Given this list of marker genes CNOT4 (NCBI Gene Id 4850), ASAP1, PHIP, PEX6, TENM3-AS1, THEMIS2, KCTD3, LINC01491, ANAPC15, NFE2L1, CCNI, RNA5SP150, ZNF81, BCO2, WLS (Wnt ligand secretion mediator), YAP1, MIR1244-3, H3-3B, FZD2, RABGAP1L-DT, GNL1, PCGF2, CLDND2, LGI4, PLCH2, JARID2, ABI2, LILRB3, PPP1R15A, TCAP, LMO4, SMAP2, ITPR1, RC3H1, GABARAP, ARHGEF1, LHX2, ST13, SAMD4A, NREP, SDC3 (NCBI Gene Id 9672), UBTF, HOXB2, BPTF, GNG12, ZBTB24, ATPAF1, RALA, ZNF771, IL21R (interleukin 21 receptor), WDTC1-DT, RAB35, RAP1GAP2, TM9SF3, CYFIP1, EEF1A1P18, POLI, MEIS2 (Meis homeobox 2), IRF2-DT, ADAMTS9, GIPR, ME1, MIR9-1HG, GDAP1, RBFOX3, IPO8, TOP3B, BMP7, PTPN4, PTPRD, FGFR4, ACVR1, PLOD1, MTERF4, RGL2, RNF217-AS1, SEC24B, ATAD2, ZMYM2, SMCHD1, TCF4, FGF5, PSMA1, ZNF385C, PLEKHA5, TSC22D1-AS1, MT-RNR1, THAP12, PAXBP1, SLC25A45, PDXK, RFX3-DT, CCDC66, KSR2, TMEM132B, LINC01145, TMEM164, TPR, LDB1, EMC8, TMBIM4, SHC4, PFKM, PRCD, ZNF148, SLC12A2 (solute carrier family 12 member 2), CLIC4, FAXDC2, GFRA1, RPL39, INTS3, NAV2, CERS6, SRCAP, HKDC1, SYDE2, CREBRF, PLCD3, ENC1, NDUFS7, NEO1, SMG9, BBIP1, DCAF13, TUBA1C (NCBI Gene Id 84790), ABCC8 (NCBI Gene Id 6833), SATB2-AS1, MRPL20, UPP2, OSBPL10, PRDM16-DT, GNG12-AS1, ENSG00000233230, SH3RF1, SRC, PCDH10-DT, TBC1D1, LAMTOR4, ITPRID2-DT, SHOC2, SAMD4B, ST8SIA2, CDC73, BBX, PPM1F, RC3H1-DT, SAP30BP, CABLES1, GEMIN6, AGAP3, LSM3, MFSD11, TAPBP, IL18R1, CUL4B, CORO1A, SEMA4D, SPRYD7, CACNA1D, PHF23, SPRYD3, PDZD7, PHF12 (PHD finger protein 12), CAND1, UBE2L3, GRK3, CHCHD7, C1QTNF2, ETS2, AP2A1, TRAV12-2, PUS7, SIRT1, USP22, USP27X-DT, GALE, CEP135, ACTB, PPP1R18, LINC01411, TEX38, CARHSP1, TENM4, LINC01138, GTF2I, STON1, SEMA3A, SLIT3-AS2, MED13L, DPAGT1, DUSP16, CALR, CDC14A, ASH2L, INO80, MAN1A2, FEM1B, CARMN, PIP4K2A, NIPBL, CELF2, ARL6IP4, CDK18, GALNT7, CXCL16, MDFIC, WDFY3, SATB1, DGKA, CBLN3 (NCBI Gene Id 651052), VAV2, ERC2, RBPMS-AS1, MACROH2A2, RAB35-AS1, PLA2G6, CDC123, SRPK2, KHNYN, UBR5, RGS16, HUNK, TIAL1 (NCBI Gene Id 8430), SNX27, LTBP3, BCOR, DLK2, PRDM16, ECE1, CLPB, RTN4, GABPB2, NEXN, RN7SL468P, TERF1, BMI1, KRTCAP2, RAPGEF2, COL13A1, RBPMS, CCT6B, DLC1, RNF217, ADORA1, HOXB-AS3, ZNF503-AS1, ST3GAL1, SLC12A5-AS1, WDR25, ZBTB48, MTAP, ZC3H4, COX6B1P7, CALHM2, DACT3-AS1, C22orf15, SLC29A3, CFAP418, RAI1, ANP32E, P2RX5, MAD1L1, KIF21A, BARHL2, PLEKHG3, NRL, YWHAB, HDGF, NDUFB8, CARMIL1, MCMBP, CCDC97, ARID4B, TSC22D1, MANF, WAC-AS1, NUDT5, NEDD4, TMEM232, DDI2, ISM1, LIG4, TMEM177, PMEPA1 (NCBI Gene Id 56937), NCOA2, ZNF703 (NCBI Gene Id 80139), MAML3 (mastermind like transcriptional coactivator 3), RAB4A, XRCC1, SLC35B3, CIZ1, KCNB1, MCTP1, DNAJC6, SCARA3 (NCBI Gene Id 7992), SLC25A32, PALS2, SH3BP5, KCNE2, TAB2, E2F5-DT, WDR26, SETP6 (NCBI Gene Id 100419178), MEF2C-AS2, EMC3 (NCBI Gene Id 55831), AKT1S1, DKK2, RAB8A, OSBPL2, RGS10, MAP2K5-DT, CRTC1, ANKRD17-DT, CD6, ZFHX2, RGS9, XPR1, FMC1-LUC7L2, STMN3, FRMD4B, EXOSC8, EGR3, ATP1B1, EIF3D, ARID1B, PRR3, SERTAD2, NCDN, ZNF687, CHD3, CNIH3, LINC01605, GVQW3 (NCBI Gene Id 387790), ENSG00000233577, SOWAHD, ENSG00000254839, DUTP7, LINC02093, NUS1, TRPC1, SAE1, DDX41, ANKHD1, KPNB1-DT, CPEB4, LRRC49, CHAF1A, SUPT6H, ATG101, HGSNAT, ALMS1, ARID3A, MYO5A, VPS25, GNAS, GCNT1, BICRA-AS2, RNF225, SRSF7, EMX2OS, FBRS, FOXB1, TLE5 (TLE family member 5, transcriptional modulator), LINC01089, EFHD2, ABCB9, RPS25, ZNF830, RAP1A, ZKSCAN2, PAX6, RPRD1B, B4GALT1, GATA6-AS1, QSOX1, HLA-F, SLC12A2-DT, MARF1, SNX15, FABP6-AS1, BAZ2B, LINC01003, EMC3-AS1, OVOL2, WAC, NEUROG2-AS1, CHST3 (NCBI Gene Id 9469), ENSG00000273582, TPM4, RUVBL2, UBE2E1, MSRB3, CNOT3, LCP2, PLEKHG1, USP34, MIR124-1HG, NCOA7 (NCBI Gene Id 135112), THAP10, ILF3-DT, PAFAH2, TRIP6, MICAL3, NOL4L, PIPOX, KRI1, NR2C2, TRUB1, GZF1, NPDC1, TSPAN4, ITGA3, LINC-PINT, NDUFC2-KCTD14, P2RX5-TAX1BP3, CSK, ATP2B4, MIR1244-4, WIF1, PURA, PRSS16, HK1, SCRIB, RCOR3, CARF, RNF182, WEE1, HS3ST5, FOXF1, LINC01918, RFX7, ENTPD4, AEBP2, MIR6784, NOG, CAPN12, DIPK2A, HNRNPLL, HDAC5 (NCBI Gene Id 23342), DBNDD2, TTI1, GALNT6, ITPR1-DT, RAB6B, SATB2, SRSF2, TMEM38A, CP, NKX6-1, ATXN10, DST, MALINC1, R3HCC1, FGD4, MAP1B, CACNB4, RBM3, BAZ1A-AS1, SMG8, SETD7, MEF2C-AS1, POLD4, PBX2, TCAM1P, MICALL1, NELFE, WFDC21P, VWA7, SMARCD1, PHGDH, TYMS, IL10RB-DT, MYL12A, PNKP, ATRX, INSYN2A, SFSWAP, ITPRID2, FGD5-AS1, STT3B, DNMT1, NDUFC2, EPHX2, RIMS1, NAP1L1, GCLC, MIR9-2HG, UBR4, SEC24B-AS1, SNORA30, XPC, PTPRD-AS1, FAXC (NCBI Gene Id 84553), MTND5P11, XPNPEP2, FLT1, LPP, SPRY4-AS1, FEZF1, TIMM44, PYM1, STOML1, KPNB1, KIAA1755, EME2, VNN2, MIR1244-2, MAP3K9, MTCO3P12 (NCBI Gene Id 107075270), CNIH4, RBMS1, FAM43A, ZNF713, CHIC1, RNF31, ENSG00000242611, NRDC (nardilysin convertase), TTL, RCOR1, PRKCSH, HOXB-AS1, CT75, MARK1, WDTC1, TTBK2, RUNDC1, TRAPPC4, HOXA5, PTGFRN, IL10RB, RREB1, SLC35A3, KMT5B, RNU4-13P, ECD, PBX1, MTF2, PSIP1, DCLK1, MAP2K4P1, STK19, JAK2, MTPN, MIR4710, HNRNPU (heterogeneous nuclear ribonucleoprotein U), EMX2, CCNC, SFXN2, RARA, KIAA0319L, BCL11A, MEF2C, SETD1B, PSME2, SCUBE3, SNORD82, IRX5, TXNL1, STC2, POLR3K, FOSL2, CDC42SE1, GOLGB1, PCM1, STAC3, SMIM7, ZBTB8OS, FGGY, KDM2A, RNU1-8P, TFAP2A, RBBP4, EIF5, MT-TF, ATXN1, PSMG1 (proteasome assembly chaperone 1), C3, CTBP2, SMARCA5, TP53TG5, SPRY2, ZNF625, ATP13A1, EIF6, ATXN1-AS1, NFIB, RN7SL494P, MIR615, HAX1, MAP2K2, ERICH6, TEX9, CKB, FEZF1-AS1, KCNMA1, PARP8, PRR5L, SPG21, PROCA1, FBXO41, NCAPG2, ZDHHC14, ZNF700, TAOK2 (NCBI Gene Id 9344), DAXX, C1orf21-DT, ENSG00000271551, IRX3, ARIH2, EFHD2-AS1, NPAS1, RBM25, VCPIP1, WDR12, SP3, LNP1, URI1, LINC00987 (NCBI Gene Id 100499405), SLC22A23, SNRNP25, FTSJ3, C1QL4, SRSF3, CAHM, TRIM44, NANOS1, GGPS1, FMC1, DCTN4, NAP1L5, EPCIP-AS1, PPRC1, ATP5MC2, ILF3, YPEL5P1, EP300, SNCA (NCBI Gene Id 6622), ZNF444, FAM167A, PPP1R3F, LRRC8B, BOC, RPL11, MYOCD, SMG1, FAM13A, GLI3, CHD4, DLX5, NPM2, PLEKHH2, USP27X, ZIC2, PLPP3, TRIM46, ANKRD17, JARID2-AS1, LIN7B, WWTR1-AS1, ANKLE2, GOSR1, VGLL4, HELB, SKIC2 (NCBI Gene Id 6499), RHOF, STRBP, SENP3-EIF4A1, GATA6, MIER1, HEXIM1, GABARAPL1, GLDC, TSPYL2, BRWD1, ZBTB45, NHERF2, SEC23IP, ACOXL, NPM1, SMG1-DT, RND1, HDDC2, TTC5 (NCBI Gene Id 91875), RAB4A-AS1, NTN1, AK7, ERICH6-AS1, SLC22A17, FAM149B1, PTENP1, JPH1, G0S2, DLX1, B4GALT6, QKI, TSC22D4, JMJD4, NKILA, ZNF704, SGK1, IKZF2, ARHGEF17-AS1, SLC4A8, PKD2, RTN1, LIN37, PDS5A, MIR3187, AARSD1, MRPS34, ANKRD13B, BICRA, PABIR2, CACNG5, KCTD15, LINC00938 (long intergenic non-protein coding RNA 938), UBE4B, ZNF860, XPO1, RBMS1P1, RBBP5, PICART1, FAM193B, SHOX2, IRF2, SMG1P3, NR2F2, MAP2K5, INPP4B, CDT1, PTGES3L-AARSD1, PTGES3L, ALG13, PIK3R5, HSD11B1-AS1, DPY19L3, SNAP47, GBA1, RC3H2, TXNIP, PTENP1-AS, CHD9NB, GALNT7-DT (NCBI Gene Id 101930370), ATXN7, PPP1R3B, TENM3, GYS1, LINC01596, ZNF521, WDFY3-AS2, SHANK1 (NCBI Gene Id 50944), ABR, CEMIP2, PABIR3, COX4I1, NCL, GTF3C6, ERG, THSD7B, ZNF625-ZNF20, LHX4, IGF2BP3, C2, ALG5, LINC01762, TBC1D9, DYRK2, AMMECR1, UBE2Q1, FBXO11, CNR1, GRK3-AS1, ADH5P2, TTLL3, WWTR1, SMG1P2, PHF21A, LEKR1, TFDP1, SRRM2, PHF3, RBL1, NCOR2, E2F5, here is a description of the gene set: species: Homo sapiens from publication Yevshin I, Sharipov R, Kolmykov S, Kondrakhin Y, Kolpakov F (PMID 30445619) Human Gene Set: ZNF513_TARGET_GENES Genes containing one or more binding sites for (ZNF513) in their promoter regions (TSS -1000,+100 bp) as identified by GTRD version 20.06 ChIP-seq harmonization.